The following is a description of a gene set: Mouse Gene Set: MIR_7041_3P Genes predicted to be targets of miRBase v22 microRNA mmu_miR_7041_3p in miRDB v6.0 with MirTarget v4 prediction scores > 80 (high confidence targets). from publication Chen Y, Wang X (PMID 31504780) species: Mus musculus, and this is the list of marker genes: Bcl2l1, Csn2, Dixdc1, Pdxdc1, Eif4h, Mog, Hps3, Myo19, Kcnh1, Syt4, Pak5, Galnt7, Glcci1, Adcy9, Atrn, Timmdc1, Dgcr2, Spsb1, Dach1, Klhl2, Exoc5 (NCBI Gene Id 218995), Gk5, Birc6 (baculoviral IAP repeat-containing 6), Gas7, Mindy2, Map3k4, Sdc1, Ube3a, Fam168a, Adamts6, Grm5, Cebpb, Pcmt1, Tshz3, Iqsec3, Cxxc5, Rpusd4, Hinfp, Chrna5, Arl13a, Grem1, B4galt4, Oacyl, Rslcan18, Brpf3, Ywhae, Cnppd1, Colq, Pkp1, Nfyc, Tada2b, Cdr2, Sema5a, Decr1, Clint1, Nrbf2, Zfp521, Pik3cd, Btbd16, Crem (NCBI Gene Id 12916), Arl13b, Pkn2, Onecut2, Nap1l1, Tbc1d8b, Il17rb, Syn1, Iglon5, Gnas, Rictor, Pptc7, Acbd3, Prps2, Zc3h6, Klf12